The following is a description of a gene set: Human Gene Set: HALLMARK_CHOLESTEROL_HOMEOSTASIS studied in species Homo sapiens from publication Liberzon A, Birger C, Thorvaldsdóttir H, Ghandi M, Mesirov JP, Tamayo P (PMID 26771021) Genes involved in cholesterol homeostasis., and this is the list of marker genes: LPL, SREBF2, CD9, ACTG1, ATF5, PDK3, TMEM97, NSDHL, CHKA, AVPR1A, STARD4, ERRFI1, ECH1, ATXN2, FBXO6, MAL2, HMGCR, GUSB, FADS2, ANXA13, DHCR7, PLSCR1, NIBAN1, GNAI1, PPARG, S100A11, CXCL16, ANXA5, ABCA2, SQLE, SEMA3B, TP53INP1 (NCBI Gene Id 94241), ACAT2, FDFT1, ACSS2, EBP, FABP5, LGMN, ANTXR2, ATF3, FDPS, PNRC1, ETHE1, PLAUR, HSD17B7, NFIL3, STX5, ALCAM, TRIB3, MVK, LGALS3, SCD, TM7SF2, CPEB2, HMGCS1, TNFRSF12A, CLU, LDLR, GPX8 (glutathione peroxidase 8 (putative)), IDI1, GLDC, SC5D, ALDOC (NCBI Gene Id 230), FASN, JAG1, LSS, PCYT2, CYP51A1 (cytochrome P450 family 51 subfamily A member 1), ADH4, CBS (cystathionine beta-synthase), GSTM2, CTNNB1, MVD, PMVK